The following is a description of a gene set: Catalysis of an oxidation-reduction (redox) reaction in which a sulfur-containing group acts as a hydrogen or electron donor and reduces NAD or NADP. Mouse Gene Set: GOMF_OXIDOREDUCTASE_ACTIVITY_ACTING_ON_A_SULFUR_GROUP_OF_DONORS_NAD_P_AS_ACCEPTOR studied in species Mus musculus, and this is the list of marker genes: Txn1, Pgk1, Selenot, Txndc2, Txnrd3, Txndc17, Dld, Nxn (nucleoredoxin), Txnrd1, Gsr, Txnrd2 (thioredoxin reductase 2)